The following is a description of a gene set: studied in species Homo sapiens The process whose specific outcome is the progression of an organismal system whose objective is to provide calibrated responses by an organism to a potential internal or invasive threat, over time, from its formation to the mature structure. A system is a regularly interacting or interdependent group of organs or tissues that work together to carry out a given biological process. Human Gene Set: GOBP_IMMUNE_SYSTEM_DEVELOPMENT, and this is the list of marker genes: UNG, SHLD2, LYN, RBM15, GATA3 (NCBI Gene Id 84828), MAPK3, IDO1, ONECUT1, KMT2A, EPHB3, XKR8, SHH, FOXE1, APLF, TGFBR2, CD28, CD40, FOXI3, SANBR, TNFRSF11A, RNF8, HOXA3, HAND2, RNF168, ADA, JARID2, CXCR5, MARCHF7, SMAD3, NSD2, MAPK1, ADAR, PRDX2, BARX1, HOXB4, KMT5C, FGF10, CD248, PCID2, COA5, HMGB1, RC3H2 (ring finger and CCCH-type domains 2), CD40LG, SAMHD1, IL10, NR5A2, IL2RA, NKX2-5, AIRE (NCBI Gene Id 326), HLA-G, ZBTB1 (zinc finger and BTB domain containing 1), TBX21, DCAF1, SPNS2, TNFAIP3, MAD1L1, PTPRC, SHLD3, FOXP3, ACOD1, CTNNB1, LRP5, MLH1, BCL3, DCLRE1C, CLCF1, CITED2, LTB, FOXL1, FAM210B, SOD1, EXO1, PARP3, EXOSC6, MSH2, BRAF, FADD, SLC15A4, ZMPSTE24, HES1, TRAF3IP2, AICDA, RIF1, NFKB2, NKX2-3, YY1 (YY1 transcription factor), CTC1, RCBTB2, TP53, RAG2, SLC40A1, POLM, BCL6 (BCL6 transcription repressor), IL2, TBX1 (T-box transcription factor 1), MAP2K1, TCF21, PDCD1, POLB, FLVCR1, NFKBIZ (NCBI Gene Id 64332), RO60, TCF3, SUPT6H, CDKN2B, PDPN, RAG1, SIX1, STAT5B, TFRC, CTNNBL1, RORC, MYB, ARTN, PKN1, ABL1, MAFB, RET, POLQ, CYREN (cell cycle regulator of NHEJ), ATAD5, CBLB, LGALS9, CCR6, FOXJ1, CACNB4, IL4, XRCC4, MAD2L2, LMO4, TYR, BCL2, POLL, ERCC1, NHEJ1, LILRB4 (NCBI Gene Id 11006), NDFIP1, ATM, STAT5A, BATF, LTBR, ID2, SWAP70, KMT5B, RC3H1, SHLD1, FOXN1 (forkhead box N1), CCR4, SRF, PBX1, MAP2K2, RAF1, HSPD1, TOX, ITCH, TGFB1, PSG9, PCYT1A, PHLPP1, PAXIP1, BCL2L11 (BCL2 like 11), IRAK3, SBDS, TNFSF13, ADAM17, TGFBR1, LILRB2, HMGB2, SLC46A2, IL27RA, PITX2, BCL11B, PSEN1, MSH6, ICOS, LRRC17, PRKDC, CD2AP, HAVCR2, PMS2, EXOSC3, HLA-E, NBN, LIG4, CDH17, CLC (NCBI Gene Id 1178), MCM3AP, STAT6, MSH3, HLA-B, CACNA1C, HMCES, LIG1, IL15, CRKL, RIPK3 (NCBI Gene Id 11035), EPB42, CCNB2, LIG3, LIPA, LTA, PPP2R3C, TP53BP1, NKX3-2, IL7R, SIX4, CD3E, ASXL1, LEF1, TNFSF4